Given this list of marker genes EHD4, MIR18A, MEOX2 (mesenchyme homeobox 2), CREB3L1, E2F2, MIR503, MIR222, SPRED1, VEGFB, APELA, NOTCH1, MIR150, MIR885, GHSR, MIR2355, MIR193A, MIR126, MIR21, MIR101-1, CIB1, SLIT2, FLT4, MIR132, MIR146A, PPP1R16B, MIR497, MIR125A, MMRN2, HDAC5, EGR3, MIR15A, ITGB1, MIR92A1, PDCD10, IL12A, MIR410, MIR199A1, MIR196A1, IL12B, IL10, CTNND1, MIR206, DLL4, KLF2, VSTM4, MIR1-1, NRP1, MIR16-1, NUS1, MIR30C1, CEACAM1, DSG2, FGF16, FLT1, ABL1, MIR34C, TNN, CLIC3, VEGFA, SYNJ2BP, AGTR1, S100A1, MIR10B, APLNR, JAK1, TGM2, MIR375, PIK3CB, SEMA3E, MIR138-1, BMP4, MIR487B, MIR221, SRPX2, CARD10, FOXC2 (NCBI Gene Id 50824), EPHB4, PARVA, FGF1, ITGA5, FGF2, EFNB2, PIK3C2A, E2F8, GREM1, OTULIN, MIR1224, MIRLET7A1, KLF4, MIR17, MIR31, TGFBR3, MIR22, TEK, RAMP2, CEMIP2, ALOX5, ITGB1BP1, ANXA1, CDH13, RHOJ, VEGFD, MIR149, RTN4, PTK2B, MIR27B, TGFB1, PDPK1, NAXE, LOXL2, MIRLET7B, JMJD6, ANGPT1, ENG, STARD13, MIR19A, PLK2, TBXA2R, MIA3, GLUL, PIK3R3, EPHA2, GATA2, MIR15B, SRF, MIR205, PKM, MIR27A, MIR296, MIR30B, GHRL (NCBI Gene Id 51738), HMOX1, ADAMTS9 (NCBI Gene Id 56999), CCBE1, MIR483, ZNF354C, MIR320A, PGF, JCAD, MIR29C, KDR, MAP2K5, EPN2, SEMA5A, FGFBP1, NR4A1, MIR494, DLL1, MIR495 (NCBI Gene Id 574453), HDAC9 (histone deacetylase 9), FGF18, MIR26A1, RECK, CDH5, MIR23A, MIR20A (microRNA 20a), MIR200C, MIRLET7F1, FUT1, CLEC14A, AKT1, THBS1, SEMA6A (semaphorin 6A), TMEM215, MIR377, MIR342, ACVRL1 (activin A receptor like type 1), MMRN1, PTGS2, NGFR, E2F7, PACSIN2, BMPER, CRIPTO, MIR361, RHOA (NCBI Gene Id 387), JMJD8, EPN1, LEF1, MICALL1, MIR34B, VEGFC, TJP1, ADGRA2, MIR19B1, MIR424, MIR34A, MIR329-1, ROBO1, ADGRG6, SMAD1, RSPO3, TSPAN18, GPLD1 (NCBI Gene Id 2822), HMGB1, NRARP, RNF213, MIR24-1, YJEFN3, HDAC7, ESM1, NR2E1, ADTRP, MIR30E, AKT3 (AKT serine/threonine kinase 3), MIR10A, here is a description of the gene set: The extension of new blood vessels from existing vessels into avascular tissues, this process includes the specialization of endothelial cells into leading tip and stalk cells, proliferation and migration of the endothelial cells and cell adhesion resulting in angiogenic sprout fusion or lumen formation. Human Gene Set: GOBP_SPROUTING_ANGIOGENESIS species: Homo sapiens